Given this list of marker genes FGFR3, GLI2, FGF10, UBR1, FGFR2, TP63, here is a description of the gene set: No identifiable superior and/or inferior lacrimal punctum. Human Gene Set: HP_ABSENT_LACRIMAL_PUNCTUM Absent lacrimal punctum species: Homo sapiens